Given this list of marker genes IGF1, ATP9A, SLC7A6OS, FOXH1, GTF2I, TLK2, COMT, EIF2AK1, DNM1, ATP1A2, GRIK2, TNRC6B, PAH (NCBI Gene Id 5053), FOXP1 (NCBI Gene Id 87246), ANKRD11, SIN3A, PCNT, CHRNB2, ASCC3, SHH, RPS20, KDM3B, TGIF1, NPAP1, MYT1L, ODC1, PIK3CA, FBXO28, CABP4 (NCBI Gene Id 57010), PACS2, KIF14, OPHN1, PDZD8, RREB1, AARS1, PMS1, TBL2, SPG7 (SPG7 matrix AAA peptidase subunit, paraplegin), PPP1R12A, ADH5, KIF11, YME1L1, PIDD1, DHCR7, CTCF, TAF6, PHF21A, GATA4, AP3B2, DRD5, DNAJC12, IGF2, IQSEC1, NDP, TNPO2, MED13, TBX1, BAZ1B, SLF2, PPP3CA, GALC, PRKCG, GNE, GABRA1, ATM, ANKRD17, PRKAR1B, SHOC2, FMR1, MAP1B, BCORL1, SPRED1, ACTL6B, PUS7, CRIPTO, TAOK1, CACNA2D1, TUBB2B, SRCAP, DEPDC5, SOX5, TSHB, MLXIPL, LGI3, NCF1 (neutrophil cytosolic factor 1), CYP27A1, BRD4, ARID2, EIF4H, SLC13A5, DYNC1I2, FLG, ZMYM2, ATP6V0A1, LIMK1, FGF12, CSNK2A1, SHMT2, HMGA2, CDH2, NFIA, FANCL, APC2, GP1BB, DLG3, KCNH5 (potassium voltage-gated channel subfamily H member 5), DYRK1A, MSH2, CACNA1H, CSGALNACT1, CASP2, SLC6A8, JARID2, TGFBR2, STEEP1, SETD5, BUD23, FKBP6, STX1A, PTEN, ARVCF, DRD4, SPEN (NCBI Gene Id 348488), SEMA4A, CHEK2, BCKDK, CNTNAP2, CELF2, SH2B1, CDH11, GNB5, KAT5, TBL1X, HSPG2, ASL, PWRN1, TRIO, BRCA2, PMS2, GLUD1, SLC1A2, HLA-DQB1, GABRA5 (gamma-aminobutyric acid type A receptor subunit alpha5), POLE, ATP6V1A, GABRB2, SNORD115-1, FANCD2 (FA complementation group D2, NCBI Gene Id 2177), SMC5, MLH1, FOXG1, RAI1, AGO1, NR2F1, TBC1D23, NIPA2, CDKN1C, ZMIZ1, SCN8A, ADGRL1, CIC, CRH, SLC2A1, ABCD1, AUTS2, SEC24C, ZNF365, THRB (NCBI Gene Id 7068), WBP11, ATP1A3, DPH1, NEXMIF, DNAJC30, PLAG1, ARPC4, CARS1, UFD1, SLC6A19, RFX7 (regulatory factor X7), ZFX, PSMB1, UPF3B, ALKBH8, TUBB3, TNFSF4, CORO1A, EIF4A2, JMJD1C, TSC1, TRAPPC14, SMARCA2, BMPR1A, SRPX2, GALT, HDAC4, SH3KBP1, SLC9A7, KANSL1, KAT8, SETBP1 (NCBI Gene Id 284262), KCNN2, KMT5B, CRBN, SPTBN1, DLL1, CDC42BPB, RAD21, CACNA1C, HERC2, TMCO1, GTF2IRD1, NLGN1, GABBR2, SPTAN1, SATB2, SOX6, CLIP2, NKAP, NAA60, MAGEL2, EBF3, NSD1, CNKSR2, HDAC8, EPCAM, SNRPN, WWOX, PRR12, NIPA1, KCNA2, ANAPC1, MKRN3, GRIN2A, GTF2IRD2, SNORD116-1, PTCHD1, CDK19 (NCBI Gene Id 23097), DHDDS, PCGF2, PHIP, MUTYH, SMC3, HNRNPK (NCBI Gene Id 3190), HCRT, METTL5, ZMYM3, CHD8, TKT, UBAP2L, WAC, TAF1, NOP56, KCNA4, DDB1, YY1, SLC38A3, CHD2 (chromodomain helicase DNA binding protein 2), LIG4, RFC2, SCN3A, FGFR1, NECAP1, GABRB3, OTC (NCBI Gene Id 5009), HNRNPH2, RIC1, KMT2B, KCNT1, NSUN6, MCTP2 (multiple C2 and transmembrane domain containing 2), GLI2, HLA-DRB1, FLI1, DALRD3 (NCBI Gene Id 55152), IQSEC2, STIL, TMEM270, CHD3, MED12L (NCBI Gene Id 57726), NUS1, IFNG, MADD, MAPK1, H4C5, KDM4B, TMEM67, ZDHHC9, PPP2CA, PIEZO2, TUBG1, BCR (BCR activator of RhoGEF and GTPase), HOXA2, ZNF292, CAPRIN1, MOG, SYNJ1, HNRNPR, ASPM, NTRK2, VPS37D, IKBKG, P2RY11 (NCBI Gene Id 5032), PRNP, SLITRK1, SRRM2, GAS1, FGD1, CDON, FGF8, PDGFRB, CYFIP2, TIAM1, CLTC, NIPBL, PRKD1, SYNGAP1, CTSH, GNAQ, SCAPER, YWHAG, CACNA1A, CACNA1B, SLC25A36, CHRNA4, POLD1, TNIK, METTL27, HDC, HEPACAM, MRPL39, NF1, UBE4A, LMAN2L, EHMT1, GRIN2D, SEMA3E (NCBI Gene Id 9723), FLII, NBN, JRK (Jrk helix-turn-helix protein), CHRNA2, ZIC2, TET3, LHCGR, POLA1, AGO2 (NCBI Gene Id 286109), TBX2, PCDH19, EEF1A2, BAP1, MED12, PANK2, GABRA2, GABBR1 (gamma-aminobutyric acid type B receptor subunit 1), NODAL, TRAK1, MAB21L1 (mab-21 like 1), DISP1, GRIA1, NBEA, HCN1, PPM1D (NCBI Gene Id 8493), UBA5, KRAS, KCNB1, SUPT16H, DPH2, ZBTB20, SZT2, TPH2, ELN, TIMM8A, TUBA1A, DCDC2, OCRL, PPP1R21, SIM1, CHRNA7, SIX3, MSH6, IVD, STS, CHD5, GNB1, RERE, NSUN2, CAMTA1 (calmodulin binding transcription activator 1), FZR1, PARS2, RSRC1, FGFR3, SMPD1, KPNA3, AP2M1, CRKL, SMC1A, PTCH1, TSC2, CDK8, SCN1A, SLC6A1, DEAF1, KCNC2, NFIB, HIRA, USP7, GABRG2, CHD7, ADNP, TANC2, DHTKD1, POGZ, PLCH1, PWAR1, NAA15, FERRY3, UBE3A, STAG2, here is a description of the gene set: Attention deficit hyperactivity disorder (ADHD) manifests at age 2-3 years or by first grade at the latest. The main symptoms are distractibility, impulsivity, hyperactivity, and often trouble organizing tasks and projects, difficulty going to sleep, and social problems from being aggressive, loud, or impatient. Attention deficit hyperactivity disorder studied in species Homo sapiens Human Gene Set: HP_ATTENTION_DEFICIT_HYPERACTIVITY_DISORDER